Given this list of marker genes MAPK1, CBL, ATXN1L, CPSF2, IQGAP3, HIPK1, DLAT, BLMH, NUDT19, DARS2, NCEH1, CIT (NCBI Gene Id 11113), CANT1, HNRNPF, MIB1, AGO1, LBR, NEMP1, SLC35B4, NPLOC4, TMEM33, FOXM1, IST1, NIPA1, PTGES3, ERH, MBTPS2, PSMD10, DESI2 (desumoylating isopeptidase 2), G3BP2, PLEKHA8, SH3PXD2A, AARS1, ZWINT, C5orf15, CEP57, CENPO, CLIC4, NUP43, MLF2, SLC39A14, CHD7, CTDSP2, SPRING1, GTF2E2, PRELID3B, SRPK1, TNKS2, KIF11, IGF2BP1, CILK1, HDLBP, VOPP1, NSUN4, PNP, KLF13, PABIR2, ARFGEF2, TMEM41A, SETD5, RFWD3, UBE3C (NCBI Gene Id 9690), PRC1, YWHAZ, KPNA6, PRR11, N4BP2, PLK1, BLTP3A (NCBI Gene Id 54887), CD2AP, MIOS, SPAG5, HJURP, PODXL, PTPN9, SRF, MED1, DNAJC9, AURKA, SIRT1, NCAPH, E2F1, VPS37B, PIP4K2C, MKI67, SSR3, DCTN5, FUCA2, MRPS10, SENP1, HNRNPUL1, LIMK1, SUDS3, SGO1 (shugoshin 1), FOXN2, TXNRD1, ANKRD52, BZW1, WIPF2, FBXO45, ANP32E, TPX2, NIPA2, HSPD1, EXO1, ZDHHC5, RBPJ, GJC1, SHMT2, SAPCD2, FANCI (FA complementation group I), TUBA1B, NUP155, CDK1, CDCA7L, RALBP1, AKIRIN1, here is a description of the gene set: The oncofetal IGF2 mRNA-binding protein 1 (IGF2BP1) promotes tumor progression in a variety of solid tumors and its expression is associated with adverse prognosis. The main role proposed for IGF2BP1 in cancer cells is the stabilization of mRNAs encoding pro-oncogenic factors. This set contains genes, consistently downregulated upon the knockdown of IGF2BP1 in various cancer derived cell lines. Furthermore, these genes showed a positive correlation in RNA expression with IGF2BP1 in the majority of TCGA tumor cohorts and their transcripts were identified as direct IGF2BP1 targets by CLIP-seq experiments. Human Gene Set: GLASS_IGF2BP1_CLIP_TARGETS_KNOCKDOWN_DN from publication Glaß M, Misiak D, Bley N, Müller S, Hagemann S, Busch B, Rausch A, Hüttelmaier S (PMID 33829040) Transcripts bound to IGF2BP1 and consistently downregulated upon IGF2BP1 knockdown in various cancer derived cell lines. species: Homo sapiens